The following is a description of a gene set: Genes up-regulated in bone marrow-derived macrophages with STAT6 knockout: control versus treated with IL4 and rosiglitazone. C57Bl/6 wild-type and STAT6 KO mice were used to study PPARg and IL-4 signaling. Bone marrow of 3 mice per group was isolated and differentiated to macrophages with M-CSF (20 ng/ml). 20 ng/ml IL-4 was used to induce alternative macrophage activation and 1 uM Rosiglitazone (RSG) was used to activate PPARg. From each mouse 4 samples were generated: 1. M-CSF, 2. M-CSF+RSG, 3. IL-4 and 4. IL-4+RSG. All compounds were added throughout the whole differentiation process, and frech media was added every other day. Control cells were treated with vehicle (DMSO:ethanol). After 10 days, RNA was isolated and gene expression profiles were analyzed using Mouse Genome 430 2.0 microarrays from Affymetrix. species: Homo sapiens from publication Szanto A, Balint BL, Nagy ZS, Barta E, Dezso B, Pap A, Szeles L, Poliska S, Oros M, Evans RM, Barak Y, Schwabe J, Nagy L (PMID 21093321) Human Gene Set: GSE25088_CTRL_VS_IL4_AND_ROSIGLITAZONE_STIM_STAT6_KO_MACROPHAGE_UP, and this is the list of marker genes: SMYD2, TMEM126A, ARNT, AKAP9, CDK19, RPF2, CIPC, ZNF573 (zinc finger protein 573), SDHD, TMEM134, TRIB3, CES3, RPL8, PCYT1A, AP4S1, TSC1, ATXN1, BTBD7 (NCBI Gene Id 55727), SORT1, RNF149, ITGAM, DNAJB5, RGS18, FRMD4B, GAPVD1, GDAP2, DPCD, TSC2, CYTH4, COX19, ESYT1, PIGN, MMGT1, POMZP3, SLC30A5, UBE2CP4, ZNF655, S100B, NMT2, DPP8, GAS8-AS1, GUSBP2, RRP1B, PIGK (phosphatidylinositol glycan anchor biosynthesis class K), SLC25A37, ABCE1, NCAPG2, AAMP, POLR2G, COX18, FAM168A, KCTD20, NDUFA1, RPS29, ZNF704, CPSF7, IGFL1, SHPRH, TMEM17, SEC61A1, RAB6A, ZCWPW2, SLC38A2, CEP85L, ANKRD6, LRCH2, SRSF1, EPRS1, RPS5, SSUH2 (ssu-2 homolog), PAK1, ATP10D, OMD, TMLHE, ISOC2, MSX2, KIAA0232, CUX1, HLA-F-AS1, NDUFA3, LYPLA1, RPLP2, MFGE8, TMEM245, RPS4Y1, RTN3, ERMARD, CLDN16, C10orf95-AS1, PEMT, CLYBL, HUWE1 (NCBI Gene Id 54789), KLK8, GTF3A, FH, PRRC2B, SLC25A3, NOP53, NOM1, HOMER1, GOLGA3, MMS19, TRAF7, ARHGAP29, COL18A1, ZNF397, RRAGB, CDC23, ZNF558, DDX17, DLG1, LINC03122, AMT, COMMD5, NCAPD2, EMP2, PYROXD2, KLHL36, RPL6 (ribosomal protein L6), CMPK1, METTL1, MLEC, NME7, TEX261, ST8SIA2, CELF1, RAC2 (Rac family small GTPase 2), RIMBP2, MCCC2, CCDC18, HDAC4, RBMX, LARP4, TTC19, TTC3, RPS4X, EPHA4, UBQLN3, PRPF38B, BABAM1, TAF1, NXPE3, SLCO4A1-AS1, C6orf136, IPO7, GALNT2, GREM1, RCAN1, PPP3CA, TMEM273, TPP2, TMBIM6, NAA50, ATPSCKMT, IDH1, TEP1, MAOB, FAM171B, SMARCC1, ARRDC4, MTA1, POLE4, EEF1B2, TMEM45B (transmembrane protein 45B), GPR155, SLC30A9, PRKDC, HDLBP, ATAD2, IGF1R, DNAAF3 (NCBI Gene Id 56162), MTREX, IARS2, ETHE1, ARHGAP35, GFM1, MPHOSPH9, ST6GAL1, SCRN2, RPL34, LTC4S, ARHGAP32, TRERF1, APH1A, SRXN1, MDGA2, AIFM1, CTNNAL1, TMEM243, LTB, BRCC3, DNAJC3 (NCBI Gene Id 5611), CACNA1D, NIN, IGIP, LRPPRC (leucine rich pentatricopeptide repeat containing), GALNT11